The following is a description of a gene set: species: Mus musculus The process whose specific outcome is the progression of the metencephalon over time, from its formation to the mature structure. Mouse Gene Set: GOBP_METENCEPHALON_DEVELOPMENT, and this is the list of marker genes: Cacna1a, Bcl2, Atp2b2, Usp9x, Prox1, Atxn2, Lmx1a, Mecp2, Ophn1, Fktn, Nr2c2, Mdk (midkine), Skor2, Arcn1, Ezh2, Sstr2, Cdk5, Scrib, Sez6, Nlgn4l, Hspa8, Mtpn, Sdf4, Glud1, Lhx1, Ncoa1, Foxp2, Tuba1a, Zbtb18 (NCBI Gene Id 30928), Myo16, B4galt2, Trp53, Neurod2, Gbx2, Kcnc1, Cplane1, Fzd4, Myh10, Ogdh, Ptf1a, Pdss2 (prenyl (solanesyl) diphosphate synthase, subunit 2), Dixdc1, Grin1, Coq8b, Sec24b, Agtr2, Gli2, Hnrnpd, Ptprs, Gdf10, Cntn1, Neurod1, Crk, Gas1, Arhgap32, Sptbn2, Slc4a7, Fcgr2b, Otx2, Gnpat, Cbln1, Sema4c (sema domain, immunoglobulin domain (Ig), transmembrane domain (TM) and short cytoplasmic domain, (semaphorin) 4C), Pfdn1, Nrxn1, Pantr2, Wnt1, Sstr3, Gpx4, Kndc1, mt-Nd4, Cbs, Hspa5 (heat shock protein 5), Ptpn11, Otx1, Rpgrip1l, Cntnap2, Faim2, Cdk5r1, Lmx1b, Igf1r, Sez6l, Foxc1, Psen1 (presenilin 1), Abl2, Prkg1, Cd3e (NCBI Gene Id 12501), Nfix, Ttc21b, Gart, Hoxa1, Rere, Atp7a, Pcnt, Cdk5r2, Kat2a, Atf2, Dab1 (disabled 1), Gabrb3, Nanos1, Pianp, Atg7, Smo, Cend1, Uqcrq, Ttll1, Atrn, Lhx5, Psap, Sstr1, Kif14, Abl1, L1cam, Serpine2, Ncstn, Herc1, Atic, Trnp1, Slc25a46, Lpar1 (NCBI Gene Id 269543), Klhl1, Dll1, Ttbk2, Zfp365, Gli1, Pax6, Ascl1, Sez6l2, Aars1, Phox2a, Gba1, Samd4b, Whrn, Rora, Ldb1, Lrp6, Ulk1, Map2k1, Hoxb1, mt-Co1, Agtpbp1, Kcne1, Abat, Grid2, Hap1, Naglu, En1 (NCBI Gene Id 13798), Comt, Wnt7a, Crkl, Clp1 (CLP1, cleavage and polyadenylation factor I subunit)